The following is a description of a gene set: Swan neck-like deformities of the fingers A swan neck deformity describes a finger with a hyperextended PIP joint and a flexed DIP joint. The most common cause for a swan neck-like deformity is a disruption of the end of the extensor tendon. Conditions that loosen the PIP joint and allow it to hyperextend, for example conditions that weaken the volar plate, can produce a swan neck deformity of the finger. One example is rheumatoid arthritis. Another cause are conditions that tighten up the small (intrinsic) muscles of the hand and fingers, for example hand trauma or nerve disorders, such as cerebral palsy, Parkinson's disease, or stroke. Human Gene Set: HP_SWAN_NECK_LIKE_DEFORMITIES_OF_THE_FINGERS studied in species Homo sapiens, and this is the list of marker genes: SLC22A4, IL10, PTPN22, NFKBIL1, CD244, SACS, PCDHGC4, CIITA, PEX5